The following is a description of a gene set: from publication Abe M, Sato Y (PMID 12197474) Vascular endothelial growth factor (VEGF) is one of the most important factors that stimulate angiogenesis and vascular permeability. To clarify the role of VEGF, we analysed a human cDNA chip containing 7267 human genes to identify genes induced by VEGF in human umbilical vein endothelial cells (HUVECs). One hundred thirty-nine cDNAs, including ninety-nine previously known and forty poorly characterized or novel sequences, were increased more than two-fold by VEGF within twenty-four hours of stimulation. Among them, only five are known to regulate angiogenesis: cyclooxygenase 2 (COX2), heparin-binding epidermal growth factor-like growth factor, early growth response 1 (EGR 1), CYR61, and angiopoietin 2. Fifty-three genes induced within the first two hours were thought to be directly induced by VEGF. Of these, Down syndrome candidate region 1 (maximum induction = 6.1-fold) was the most profoundly induced, followed by Mifl (KIAA0025; 5.5-fold), COX2 (4.7-fold), EGR 3 (3.7-fold), EGR 2 (3.2-fold), bactericidal/permeability-increasing protein (3.1-fold), and CD1B antigen, b polypeptide (3.1-fold). In addition to the genes mentioned above, there were many poorly characterized or novel genes induced by VEGF. Further analysis of these genes may aid in the elucidation of the molecular mechanisms of angiogenesis or vascular permeability stimulated by VEGF. Human Gene Set: ABE_VEGFA_TARGETS_2HR studied in species Homo sapiens Genes up-regulated in HUVEC cells (endothelium) at 2 h after VEGFA stimulation., and this is the list of marker genes: XPO7, BPI, RCAN1, TKTL1, PPL, EIF1, APOE, NR4A1, CARS1, SERPINB2, CUX1, LDLR, PRKCD, TNFRSF14, CD1B, ELAVL4, LINC02361, RAPGEF1, CYP1A1, MCM2, ZCCHC14, POLR1G, PPY, DAPK3, AURKC, PDCD1, LAD1, CDKN1A, NELFE, PLPP3, PTGS2, HERPUD1, HBEGF, UPP1, CDR1